Given this list of marker genes Eya2, Jph4, Pmf1, Rph3al, Ppt1, Alkbh1, Foxp4, here is a description of the gene set: studied in species Mus musculus Mouse Gene Set: MIR_6933_5P from publication Chen Y, Wang X (PMID 31504780) Genes predicted to be targets of miRBase v22 microRNA mmu_miR_6933_5p in miRDB v6.0 with MirTarget v4 prediction scores > 80 (high confidence targets).